Given this list of marker genes HTR4 (5-hydroxytryptamine receptor 4), HTR2C, RNLS, DRD1, DRD3, APP, CAV2, ADCY5 (adenylate cyclase 5), COMT, ALK, NCSTN, GNA14, RGS4, GNG2, SULT1A4, HTR2A, HTR3B, RGS9, SULT1A3, HTR7, PRKN, SLC1A1, GSK3A, RGS8, KLF16, ABL1, PTGER1, HTR2B, HDAC2, PRMT5, VPS35, DRD2, NHERF1, GSK3B, GNAS (GNAS complex locus), DRD5, HTR3D, HTR1A, GNB1, HTR3C, CHRNA9, C14orf28, HTR6, GNAO1 (G protein subunit alpha o1), LRRK2, PALM, DRD4, HTR3A, GNA11, ADCY6, GNB5, GNAL, NR4A3, ARRB2, CHRNA10, TGM2, APLP1, HTR3E, SIN3A, MIR17, DTNBP1, FLNA, PRKD1, here is a description of the gene set: Any process that results in a change in state or activity of a cell or an organism (in terms of movement, secretion, enzyme production, gene expression, etc.) as a result of a monoamine stimulus. A monoamine is any of a group of molecular messengers that contain one amino group that is connected to an aromatic ring by ethylene group (-CH2-CH2-). Monoamines are derived from the aromatic amino acids phenylalanine, tyrosine, histidine and tryptophan. Human Gene Set: GOBP_RESPONSE_TO_MONOAMINE species: Homo sapiens